Given this list of marker genes MIR17HG, AKT1, FOXP1, CD74, SLC46A2, ADA, RAG1, FNIP1, TNFRSF21, IL7R, MYC, TSC22D3, BCL3, RIPK1, BCL6, MIF, BMP4, BBC3, LGALS16, EBF4, GIMAP8, PRKCQ, PKN1, CLC, PIP, BCL10, ADAM8, ZC3H8, CRKL, LGALS9, PRKD2, LIPA, CASP7, DOCK8, NFKBIZ, BCL11B, JAK3, CD274, LGALS3, HSH2D, CHEK2, KIFAP3, IL2RA (NCBI Gene Id 3559), GLI3, PRELID1, EFNA1, CD3G, LYN, IL10, RIPK3, SIVA1, RORC, KDELR1, LMBR1L, PTCRA, PDCD1, NOC2L, ORMDL3, CCL5 (NCBI Gene Id 8147), IL2, BCL2, FAS (NCBI Gene Id 355), PERP (NCBI Gene Id 64065), HIF1A, BCL2L11, DFFA, BAX, BIRC7, WNT5A, TGFB2, FASLG, IDO1, BAK1, GPAM, P2RX7, ARG2, DNAJA3, FADD, ST3GAL1, TP53, IRS2, TRAF3IP2, AURKB, BTK, CD27, SLC39A10, here is a description of the gene set: Human Gene Set: GOBP_LYMPHOCYTE_APOPTOTIC_PROCESS species: Homo sapiens Any apoptotic process in a lymphocyte, a leukocyte commonly found in the blood and lymph that has the characteristics of a large nucleus, a neutral staining cytoplasm, and prominent heterochromatin.